Given this list of marker genes PFAS, SSBP3, LHX1, SOX9, BMP5, COL2A1, DDX10, here is a description of the gene set: studied in species Homo sapiens Human Gene Set: GOBP_ANTERIOR_HEAD_DEVELOPMENT The process whose specific outcome is the progression of the anterior part of the head over time, from its formation to the mature structure.